The following is a description of a gene set: part of: Toll Like Receptor 10 (TLR10) Cascade; Toll Like Receptor 5 (TLR5) Cascade Reactome Pathway: MyD88 cascade initiated on plasma membrane studied in species Homo sapiens Mammalian myeloid differentiation factor 88 (MyD88) is Toll/interleukin (IL)-1 (TIR)-domain containing adapter protein which plays crucial role in TLR signaling. All TLRs, with only one exception of TLR3, can initiate downstream signaling trough MyD88. In the MyD88 - dependent pathway, once the adaptor is bound to TLR it leads to recruitment of IL1 receptor associated kinase family IRAK which is followed by activation of tumour necrosis factor receptor-associated factor 6 (TRAF6). TRAF6 is an ubiquitin E3 ligase which in turn induces TGF-beta activating kinase 1 (TAK1) auto phosphorylation. Once activated TAK1 can ultimately mediate the induction of the transcription factor NF-kB or the mitogen-activated protein kinases (MAPK), such as JNK, p38 and ERK. This results in the translocation of the activated NF-kB and MAPKs to the nucleus and the initiation of appropriate gene transcription leading to the production of many proinflammatory cytokines and antimicrobial peptides., and this is the list of marker genes: RPS6KA2, PPP2CB, UBE2N, IKBKG, UBB, UBA52, N4BP1, UBC, DUSP7, MAPKAPK2, NFKBIB, LRRC14, CUL1, IKBIP, NLRC5, NFKBIA, PPP2CA (NCBI Gene Id 5515), MAPKAPK3, TLR5, NLRX1, HMGB1, PELI1, MAPK1, DUSP6, MYD88, ATF1, RPS6KA1, MAPK14, MAPK11, MAPK8, FOS, NFKB1, S100B (NCBI Gene Id 6285), MAPK3, RELA, FBXW11, TRAF2, DUSP3, MAP2K4, IKBKB, TIFA, BTRC, DUSP4, AGER, NKIRAS2, TRAF6, PELI2, NFKB2, RIPK2 (receptor interacting serine/threonine kinase 2), MAPK9, CREB1, UBE2V1, N, APP, TAB1, MAPK10, USP18, VRK3, S100A12, ALPK1, PELI3, MAPK7, PPP2R1B, NOD1, RPS6KA3, SAA1, CHUK, CASP8, PPP2R5D, MAP3K7, MAP2K3, MAP3K1, NKIRAS1, TAB3, RPS6KA5, ATF2, JUN, MEF2C, MAP2K6, PPP2R1A, ELK1, TP53, fliC, IRAK1, USP14, MAP2K7, TAB2, SKP1, MEF2A, NOD2, TNIP2, RPS27A, MAP2K1, IRAK4, TLR10, IRAK2, ECSIT, MAP3K8